The following is a description of a gene set: species: Mus musculus Mouse Gene Set: GOBP_REGULATION_OF_BLOOD_VOLUME_BY_RENIN_ANGIOTENSIN The process in which the renin-angiotensin system controls the rate of fluid intake and output into the blood., and this is the list of marker genes: Agtr1a, Rps6ka2, Agtr1b, Ren1, Nkx2-1, Agtr2, Ace2, Cyba, Drd3, Agt, Klk1b26, Tacr1